The following is a description of a gene set: studied in species Homo sapiens Human Gene Set: GOBP_PEPTIDYL_LYSINE_METHYLATION The methylation of peptidyl-lysine to form either the mono-, di- or trimethylated derivative., and this is the list of marker genes: SETD2 (NCBI Gene Id 84184), SMYD2, EEF1AKMT3, METTL18, EEF1AKMT2, VCPKMT, METTL21C, EEF2KMT, EHMT2, SETD3, EEF1AKMT1 (NCBI Gene Id 221143), ANTKMT, CSKMT, ATPSCKMT, SETD6, SETD7, EHMT1, KMT5A